Given this list of marker genes Gspt2, Mtrf1l, Mtrf1, Mrpl58, Etf1, Mtrfr, Gspt1, here is a description of the gene set: Mouse Gene Set: GOMF_TRANSLATION_TERMINATION_FACTOR_ACTIVITY Functions in the termination of translation. studied in species Mus musculus